The following is a description of a gene set: species: Homo sapiens Human Gene Set: REACTOME_ACTIVATION_OF_ANTERIOR_HOX_GENES_IN_HINDBRAIN_DEVELOPMENT_DURING_EARLY_EMBRYOGENESIS Activation of anterior HOX genes in hindbrain development during early embryogenesis, and this is the list of marker genes: H2AC20, CNOT6, NCOA3, H2BC17, H4C11, POLR2J, JUN, CREBBP, H2AC18, EP300, HOXA4, RARA, H4C4 (H4 clustered histone 4), POLR2K, H3C11, PAXIP1, EZH2, H4C8, H2BC15, RARG, H3C1, KMT2C, H2BC7, AJUBA, HOXA2, RBBP4, H3C2, POLR2D, H4C15, H2AZ2, HOXD1, HOXD4, H2BC14, EED, PAGR1, H2BC13, POLR2A, H3C13, SUZ12, POLR2G, NCOA6, POLR2F, POLR2C, PKNOX1, H2BC12, H3-3A, CNOT9, H3C8, H3-3B (H3.3 histone B), EGR2 (early growth response 2), HOXB1, H3C10, H4C13, H2BC9, H4C5 (NCBI Gene Id 8367), H2AC4, KMT2D, H2AC7, YY1, H2AC6, H2BC12L, H4C1, WDR5, HOXA1, ASH2L (NCBI Gene Id 9070), H4C14, H2BC3, H3C15, POLR2L, POLR2E, PIAS2, HDAC3, RARB, H4C12, H3C14, H3C3, H2BC26, H2AC8, PCGF2, POLR2B, MAFB, H2BC6, KDM6A, H2BC8, H2BC5, H3C6, H2AB1, H4C6, H2AJ, H2BC10, H2AC19, RBBP7, H2BC11, RBBP5, MEIS1, H2BC4, RXRA, H4C2, HOXC4, HOXB4, POLR2H, H3C12, DPY30, HOXB2 (NCBI Gene Id 3212), NCOR1, H4C9, HOXD3, H2AX (H2A.X variant histone), PAX6, CTCF, H3C7 (NCBI Gene Id 8968), POLR2I, ZNF335, H4C3, H3C4, H4C16, HOXA3, H2BC1, PBX1, H2AC14, HOXB3, H2BC21